The following is a description of a gene set: Human Gene Set: GSE11924_TH1_VS_TH2_CD4_TCELL_DN studied in species Homo sapiens After activation, CD4+ helper T (Th) cells differentiate into distinct effector subsets. Although chemokine (C-X-C motif) receptor 5-expressing T follicular helper (Tfh) cells are important in humoral immunity, their developmental regulation is unclear. Here we show that Tfh cells had a distinct gene expression profile and developed in vivo independently of the Th1 or Th2 cell lineages. Tfh cell generation was regulated by ICOS ligand (ICOSL) expressed on B cells and was dependent on interleukin-21 (IL-21), IL-6, and signal transducer and activator of transcription 3. However, unlike Th17 cells, differentiation of Tfh cells did not require transforming growth factor b (TGF-b) or Th17-specific orphan nuclear receptors RORa and RORg in vivo. Finally, naive T cells activated in vitro in the presence of IL-21 but not TGF-b signaling preferentially acquired Tfh gene expression and promoted germinal-center reactions in vivo. This study thus demonstrates that Tfh is a distinct Th cell lineage. from publication Nurieva RI, Chung Y, Hwang D, Yang XO, Kang HS, Ma L, Wang YH, Watowich SS, Jetten AM, Tian Q, Dong C (PMID 18599325) Genes down-regulated in comparison of Th1 cells versus Th2 cells., and this is the list of marker genes: CFAP276, ADK (adenosine kinase), CD300LD, PON3, CSGALNACT2, SELENOW, TMEM106B, GPM6B, GFI1, RABL3, ARF4, GSN, ZPBP2, MAP4K3, ZFP1, NIPAL1, GTDC1, RAP1B, IL12RB1, ITGAX, AFF1, HSD17B12, TMEM168, MCFD2, CASP1, FOXQ1, CAMLG, FAM20B, CYP11A1, HS3ST1, TACSTD2, OAT, FAAP20, MGRN1, DPY19L3, TSPAN6, CTSK, LY96, HIPK2, LTBP3, B3GALT5, CYP1B1, NR3C1, TCF21, SPECC1, GLB1, GFPT2, SLC38A10, DACH2, LAMC2, NPTX1, CEBPA, TVP23B, TBK1, NSMCE1-DT, GPAM, BCAR3, CCDC126 (coiled-coil domain containing 126), FAF2, TMTC2 (transmembrane O-mannosyltransferase targeting cadherins 2), DRAM2, IKZF3 (NCBI Gene Id 22806), PSEN1, TSPAN33, IBTK, RSU1, CA5A, VKORC1, YIPF5, SLFN5, HYOU1, MMRN2, ARID3A, TAFAZZIN, CFAP57, ALG11, IQCF1, RCL1, MGAT4C, GZF1, ZMAT4, RBP4, SFT2D2, ZNF446, ACBD7, CLCN4, MMP10, OAZ2, RELCH, ENTREP2, HOMER2 (homer scaffold protein 2), HSD17B3, YBX2, STAC, KIF3A, GHRL, DMAC2L, AKR1C3, MOXD1, NMT1, RND3, PRDX5, DAAM1 (dishevelled associated activator of morphogenesis 1), RAB33B, SH2B2, SDE2, ANKH, HIGD2A, SLC12A2, CREB3, ADGRA3 (adhesion G protein-coupled receptor A3), HSPA13, MVP, MARCKS, FCMR, CANX, USP16, WDFY4, MZB1, DLG1, BTAF1, FAM229A, VAMP5, C19orf33, MTMR6, CCR3, TMEM63A, RNF152, TMEM167B, TBC1D10A, ST3GAL6, GOLGA3, MAG, TMEM263, PPIL4, NUMB, ITM2A, CA2, LGALS8, NT5C3A, SLC25A19, MYOCD, SERINC5, FYTTD1, NUS1, TCIM, GFPT1, HCCS, FLYWCH2, NIPSNAP3A, VPS35, GPC5, ORMDL3, MT2A, NPNT, SEC22B, BCL2L15, CXCL1, CRHR2, PPARG, SLC35F5, HEXIM2, SLPI, GOLPH3L, PNMA5, ADAMTS15, RALB, RAB1A, SFT2D3, ERLIN1, HMX3, TSGA13, CDCP1, EPCIP, GJA1, MAP3K2, TFAP2E (transcription factor AP-2 epsilon), TMED9, COL18A1, SIK2, SNX2, UBE3D, LAPTM4A, VPS26C, TSC22D2, RAP2A, PRXL2A, ATP6V0E1, ZNF260, TRIO, ADAM12, SUGCT, TFG, ARV1 (NCBI Gene Id 64801), SDF2L1, RAB27B, LIX1, FAM219A (NCBI Gene Id 203259), SPEG